Given this list of marker genes TRAPPC8, NIPBL, SCAF8, ADCY7, STX16, RBM5, CRBN, TRIM22, RSRC2, CSNK1G2, ATG12, TAF1C, DDX5, ACTR2, BNIP2, MBD4 (methyl-CpG binding domain 4, DNA glycosylase), KDM5A, SETD2, IK, UBXN4, PTPRC, ZNF394, SRSF6, SCAF11, NXF1 (NCBI Gene Id 10482), H3-3B, BIRC2, HNRNPDL, VPS16, SNX6, ARHGAP45, RBM22, YPEL5, ARHGAP4, NACA, DDX3X, WASHC2C, TTC31, UBP1, SRSF5, ITGA4, ADPGK, SF3B1, PAPOLA, MBNL1, IKBKB, MSL1, MBD1, ZXDC, YTHDC1, CHD1, HECA, CDV3, VPS13C, STK38, BPTF, UFM1, RPL34, RSRP1, RBM39, PHF11, CCNL1, TYK2, here is a description of the gene set: species: Homo sapiens Human Gene Set: GNF2_DDX5 Neighborhood of DDX5 Neighborhood of DDX5 DEAD (Asp-Glu-Ala-Asp) box polypeptide 5 in the GNF2 expression compendium